The following is a description of a gene set: species: Homo sapiens Ependymoma Human Gene Set: HP_EPENDYMOMA The presence of an ependymoma of the central nervous system., and this is the list of marker genes: ERBB2, TP53, IFNG, MLH1, TSC2, CHEK2, CDKN2C, IDH1, CDKN2A, MDM2, ZFTA, APC, CDKN1B, NF2, CDKN2B, TSC1, CDKN1A (NCBI Gene Id 1026), SETBP1, MEN1